The following is a description of a gene set: species: Mus musculus SUMOylation of SUMOylation proteins Mouse Gene Set: REACTOME_SUMOYLATION_OF_SUMOYLATION_PROTEINS, and this is the list of marker genes: Nup88, Nup62 (nucleoporin 62), Nup133, Rae1, Nup155, Sec13, Nup107, Sumo2, Nup54, Nup35, Nup50, Nup37, Nup58, Nup93, Nup43, Nup42, Pias4, Nup98, Ube2i, Seh1l, Tpr, Nup214, Nup160, Sumo1, Topors, Nup153, Nup85, Pom121, Ndc1, Ranbp2, Nup188, Nup205, Nup210, Aaas